Given this list of marker genes Kcnj6, Slc12a8, Rgs2, Slc16a2, Slc8a2, Slc15a1, Slc39a5 (solute carrier family 39 (metal ion transporter), member 5), Scnn1a, Akt1, Agt, Kcnk9, Fyn, Hcn4, Slc30a8, Slc6a20a, Slc2a1, P2rx1, Scnn1b, Cnga3, Per2, Kcnn4, Atp1a3, Cacna1d, Arl6ip1, Kcnq1, Slc3a2 (NCBI Gene Id 17254), Acsl6, Trpv1, Slc22a4, P2rx5, Cltrn, Slc12a1, Cacna1c, Asic5, Ppp3cc, Wnk1, Trpv2, Atp1b2, Slc43a1, Slc31a1, Slc6a6, Atp4a, Slc7a2, Slc12a6, Atp1a4, Rgs4, Slc2a5, Slc38a4, Trpv5, Kcnj14, Ppp3r1, Trpv3, Acsl1, Cacna1f, Atp1a2, Atp1b3, Slc7a5, Slc39a14, Grm1, Slc7a3, Slc6a13, Kcnj3, Kcnj9, Slc39a4, Slc38a2, Wnk4, Abcc1, Slc38a3, Acsl5, Slc19a1, Prkcd, Kcnj1, Psen1, Slc6a1, Kcnj16, Slc11a2, Trpm2, Arl6ip5, Cln8, Slc27a5, Cacna1e, Slc7a1, Slc6a7, Arg2, Slc17a8, Itgb1, Trpv4, Slc9a2, Lrrc8c, Cacna1b, Slc27a1, Slc30a5, Slc12a7, Trpm1, Slc15a2, Cacna1a, Akt2, Slc6a14, Lrrc8d, Slc7a8 (solute carrier family 7 (cationic amino acid transporter, y+ system), member 8), Wnk3, Slc46a1, Trpm4, Ppp3ca, Atp1b1, Slc15a3, Kcnj10, Slc9c1, Kcnj5, Slc22a2, Prnp, Slc36a2, Lrp2, Slc15a4, Steap2, Slc9a3, Atp4b, Ms4a1, Slc24a4, Gfap, Kcnj4, Cav1, Ace2, Scnn1g, Slc38a5, Atp1a1, Hcn2, Akap5, Lrrc8b, Slc39a6, Slc8a3, Slc36a1, Slc7a11, Lrrc8e, Slc34a1, Slc5a6, Abcc9, Arg1, Shoc2, Slc39a10, Lcn2 (NCBI Gene Id 99344), Pawr, Nherf1, Kcnj2, Slc1a4, Ppp3cb, Slc24a2, Adrb1, Slc30a1, Slc1a5, Irs2, Dlg1, Kcne2, Tspo2, Iscu, Slc1a2, Slc38a1, Nalf1, Ank3, Ntsr1 (neurotensin receptor 1), Wnk2, Cd36, Slc9a1, Slc12a3, Slc8a1, Slc9a6, Slc12a2, Ppp3r2 (NCBI Gene Id 230166), Slc6a5, Slc12a5, Nalf2, Grm6, Adrb2, Slc39a12, Slc9a7, Slc39a8, Trpv6, Kcnj15, Kcnd3, Kcnj11, Kcnk5, Kcnj12 (potassium inwardly-rectifying channel, subfamily J, member 12), Kcnh2, Slc46a2, Tnf, Aqp8, Slc9a9, Fxyd2, Slc5a1, Slc6a9, Slc9a5, Slc1a6, Septin2, Slc1a3, Arhgef11, Slc28a1, Kcnj13, Slc1a1, Thbs1, Slc47a1, Atp12a, Slc6a20b, Slc9a4 (solute carrier family 9 (sodium/hydrogen exchanger), member 4), Slc12a4, Slc5a2, Kcnj8, Slc43a2, Slc2a10, Lrrc8a, Scn5a, Cacna1s, Agtr1a, Ifng, Slc39a11, here is a description of the gene set: Mouse Gene Set: GOBP_IMPORT_ACROSS_PLASMA_MEMBRANE The directed movement of some substance from outside of a cell, across the plasma membrane and into the cytosol. studied in species Mus musculus